Given this list of marker genes Apoa2, Agt, Agtr1a, Dbi (NCBI Gene Id 13167), Apoe, Apoa1, Agtr1b, Apoa4, here is a description of the gene set: Mouse Gene Set: GOBP_POSITIVE_REGULATION_OF_COA_TRANSFERASE_ACTIVITY Any process that activates or increases the frequency, rate or extent of CoA-transferase activity. studied in species Mus musculus